The following is a description of a gene set: Genes negatively differentially expressed in cell type: CD4+ T cell upon treatment with cytokine: IFN-ε in mouse lymph nodes in vivo. from publication Cui A, Huang T, Li S, Ma A, Pérez JL, Sander C, Keskin DB, Wu CJ, Fraenkel E, Hacohen N (PMID 38057668) Cytokines mediate cell-cell communication in the immune system and represent important therapeutic targets. A myriad of studies have highlighted their central role in immune function, yet we lack a global view of the cellular responses of each immune cell type to each cytokine. To address this gap, the authors created the Immune Dictionary, a compendium of single-cell transcriptomic profiles of more than 17 immune cell types in response to each of 86 cytokines (>1,400 cytokine-cell type combinations) in mouse lymph nodes in vivo. A cytokine-centric view of the dictionary revealed that most cytokines induce highly cell-type-specific responses. For example, the inflammatory cytokine interleukin-1β induces distinct gene programmes in almost every cell type. A cell-type-centric view of the dictionary identified more than 66 cytokine-driven cellular polarization states across immune cell types, including previously uncharacterized states such as an interleukin-18-induced polyfunctional natural killer cell state. species: Mus musculus Mouse Gene Set: CUI_T_CELL_CD4_IFNE_RESPONSE_DN, and this is the list of marker genes: Uba52, Jun, Tsc22d3, Hspa1a, Junb, Hspa1b